Given this list of marker genes GGA2, DNAJC13, HLA-H, NAPEPLD, ZMPSTE24 (zinc metallopeptidase STE24), HLA-DRA, WASHC5, SNX30, ABCA7, WASHC2C, ABCB6, SNX3, REP15, MR1, RABEP1, WASHC3, TMEM30A, HGS (NCBI Gene Id 9146), PLD3, ZFYVE16, LAMP5 (lysosomal associated membrane protein family member 5), CD274, CLVS2, STAM, HLA-E, RCC2, CFTR, FZD5, RAB21, NSG1, SNX12, MTMR4, SNX7, MON2, HLA-F, SNX13, CD8B, VAC14, TICAM2, ATP13A3, VAMP3, BOK, EGFR, APP, VPS41, WDR91, MARCHF8, KIR2DL4, EPS15, ITCH (itchy E3 ubiquitin protein ligase), HLA-B, NTRK1, CLIP3, NSG2, STAM2, STX7 (syntaxin 7), GPNMB, GPR65, SNX5, PLA2G4E, SNX2, OSBPL6, RAC1, TSG101, FIG4, PDLIM4, EEA1, SNX16, PLPP2, GGA3, SLC30A10, KIAA0319, SLC11A2, LDLRAD4, PLA2G4B, CLCN3, EPHA8, PLEKHF2, SNX19, CLEC10A, HLA-G, TOM1, MCOLN3, TBC1D3, VAMP8 (vesicle associated membrane protein 8), VTI1B, FCGR1A, WDR81 (NCBI Gene Id 780925), CAV1, DKK1, MAPKAP1, WLS, EHD1 (EH domain containing 1), WASH3P, SLC15A4, RBSN, GGA1, KIF16B (kinesin family member 16B), BAIAP3, HSD17B6, PI4K2B (phosphatidylinositol 4-kinase type 2 beta), WASHC1, RABGEF1, SLC9A6, KCNH1, PMEPA1, SORCS2, DAGLA, SNX20, STEAP4, SNX1, CMTM6, TMEM184A, INPP5F, ARC, FCGR1BP, OCRL, KREMEN2, MARCHF1, APPL1, TMEM9B, SORL1, NEU3 (neuraminidase 3), TPCN1 (NCBI Gene Id 56236, two pore segment channel 1), LLGL1, RAB4B, ZFYVE28, ATP7A, RUFY1, SNX21, LITAF, HLA-C, PIKFYVE, SPHK1 (NCBI Gene Id 8877), MMGT1, SH3GL1, EHD4, WASH6P, GRIA1, CLCN4, TMEM63B, IFITM3, B2M, LRP6 (NCBI Gene Id 4040), RAB4A, CD207, ATP11C, STX12, VPS13B, EPHA4, RAB31, TMEM163, RAB5B, RAB11FIP5, WASHC4, SLC9A9, CLVS1, SNX6, SH3GL3, INPP4A, UBXN6, SNX27 (sorting nexin 27), ANXA1, FCMR, ARF6, PSEN1, SLC9A3, SNX8, DOP1B, HLA-A, SLC1A1, NTRK2, OR51E2, INPP5B, TMEM63A, VPS33B, HPS6, EPHB1, APPL2 (NCBI Gene Id 55198), SLC5A7, SLC31A1, WASHC2A, MTMR2, ATP11B, SLC39A14, DTX3L, RAB5C, CLN3, LAMP3, FGD2, ATP9A, ZFYVE9, TLR9, PML, SLC35D3 (solute carrier family 35 member D3), MARCHF3, SNX4, WNT3A, ARL8B, SYNDIG1, RAB5A, ATP13A4, PI4K2A, GRIPAP1, ENTREP1, RAB14, here is a description of the gene set: species: Homo sapiens Human Gene Set: GOCC_EARLY_ENDOSOME_MEMBRANE The lipid bilayer surrounding an early endosome.